Given this list of marker genes LPIN2, ANKRD55, STAT4, NOD2, PTPN11, BRAF, TRAPPC2, POLR3A, PTPN22, HYAL1, ANKH, MAP2K1, PTPN2, IL2RB, F8, CD247, TNFRSF11B, PRG4, IL2RA, here is a description of the gene set: Human Gene Set: HP_ABNORMAL_SYNOVIAL_MEMBRANE_MORPHOLOGY Any structural anomaly of the synovium, which is a membrane that lines the cavity of synovial joints and consists of a lining layer of macrophage-like synoviocytes and fibroblast-like synoviocytes, as well as a sublining of connective tissue. Synovial cells are thought to contribute to joint homeostasis by secreting various factors such as hyaluronic acid and lubricin important for joint lubrication and function, as well as disposing of the waste products. species: Homo sapiens Abnormal synovial membrane morphology